The following is a description of a gene set: A decreased concentration of C-peptide in the circulation. Since C-peptide is secreted in equimolar amounts to insulin, this feature correlates with reduced insulin secretion. Human Gene Set: HP_REDUCED_C_PEPTIDE_LEVEL Reduced C-peptide level species: Homo sapiens, and this is the list of marker genes: PDX1, INS, GCK, KCNJ11, CNOT1, NAB2, STAT6